Given this list of marker genes Dgkb, Agk, Dgke, Dgkh, Dgkk, Dgkz, Dgkd, Dgka, Dgkq, Dgkg, Dgki, here is a description of the gene set: Catalysis of the reaction: a 1,2-diacyl-sn-glycerol + ATP = a 1,2-diacyl-sn-glycero-3-phosphate + ADP + H+. species: Mus musculus Mouse Gene Set: GOMF_ATP_DEPENDENT_DIACYLGLYCEROL_KINASE_ACTIVITY